Given this list of marker genes GNRHR, CRHBP, MGARP, GNRHR2, UMODL1, GPR173, here is a description of the gene set: Human Gene Set: GOBP_CELLULAR_RESPONSE_TO_GONADOTROPIN_RELEASING_HORMONE Any process that results in a change in state or activity of a cell (in terms of movement, secretion, enzyme production, gene expression, etc.) as a result of a gonadotropin-releasing hormone stimulus. Gonadotropin-releasing hormone (GnRH) is a peptide hormone responsible for the release of follicle-stimulating hormone (FSH) and luteinizing hormone (LH) from the anterior pituitary. GnRH is synthesized and released by the hypothalamus. species: Homo sapiens